The following is a description of a gene set: studied in species Mus musculus Mouse Gene Set: GOBP_RESPONSE_TO_ENDOGENOUS_STIMULUS Any process that results in a change in state or activity of a cell or an organism (in terms of movement, secretion, enzyme production, gene expression, etc.) as a result of a stimulus arising within the organism., and this is the list of marker genes: Crebbp, Prlr, Dab2ip, Lpin1, Scx, Kcnc2, Npc1, Rbbp7, Mir206, Zfp747, Bmp8a, Gck, Otop1, Car2, Gpc3, Rack1, Sh3gl2, Ndnf, Adamts12, Fgb, Pkd1l1, Lemd2, Sh2b2, Snai2, Sgcb, Cask, Prkcd, Ripk1, Fcer1g, Apoc3, Tet1, Igfbp5, Itgb3, Cdkn1c, Serpine1, Pdcd7, Dll1, Sin3a, Smurf2, Lyn, Ptk2, Strn3, Lepr, Aqp1, Ndel1, Myd88, Trem2, Erfe, Pdk4, Notch1, Inhbb, Tgfbr3, Ovol2, Mir223, Agxt, Nrp2, Magi2, Dcp1a, Zfp747l1, Ints9, Phip, Axl, Sox9, Map1b, Emd, Ppp3ca, Abcb1a, Thbs1, Bcar3, Lpl, Fam83g, Wnt10b, Tek, Akap8, Akr1c13, E2f1, Rdx, Ctsb, Enpp1, Hmgb1, Acod1, Esrrb, Tbl1x, Mir146, Igf1, Gjb2, Brms1, App, Ezh2, Cdh13, Gstp1, Ucp2, Epb41l5, Rps3, Fgf20, Adamtsl2, Sh3glb1, Creb1, Gria1 (NCBI Gene Id 72995), Lpin3, Mc4r, Epha2, Prlh, Scgb2a2, Bmp5, Pparg, Hgf (hepatocyte growth factor), Slit3, Cdkn1a, Cfl1, Dstyk, Mir219a-1 (microRNA 219a-1), Foxa1, Acta2, Asns, Gdf7, Agl, Fkbp8, Elk1, Vtn, Kdm4c, Nr0b1, Ext2, Mir142, Ctsd, Brd8, Ubr5, Ptprd, Pf4, Ntf5, Bcar1, Sp7, Padi2, Slc30a10, Fgf16, Prkd1, Zmiz1, Blvra, Cdc5lrt6, Foxc2, Mbd5, Crk (v-crk avian sarcoma virus CT10 oncogene homolog), Hmgcs2, Sfrp4, Sema6a, Wbp2, Cd109 (CD109 antigen), Irs1, Fbp1, Mir338, Bex1, Ces1f, Lta4h, Mcm7 (NCBI Gene Id 17220), Mir708, Src, Ltbp4, Pck2, Chrd, Cry1, Ccn1 (NCBI Gene Id 99596), Rhod, Mir574, Sos2, Ccna2, Elavl4, Lbh, Suds3, Nck1, Ube2o, Oxtr, Rangap1, Slx4, Slc4a7, Mir675, Rab14, Kcnj8, Fgf9, Angpt2, Mir124a-1hg, Mtor, Itga8, Skor2, Ncor2 (NCBI Gene Id 20602), Tlr4, Ogt, Pde3b, Fbxo32, Qrfprl, Il10, Cstf2, Snx1, Peg10, Hyal2, Ptpn1, Ero1a, Zeb2, Glp2r, Nog, Gas6, Mn1, Wfikkn1, Il17f (interleukin 17F), Ednrb, Kmt2a, Xbp1, Pdcd5, Adamts7, Spry1, Kat2b, Chrdl1, Ugcg, Ccl19-ps6, Ntrk3, Stat2, Itgb6 (NCBI Gene Id 93831), Actr3, Igfbp1, Alad, Sstr5, Fer, Hadh, Abcb11, Ghrl, Mir219a-2, Nodal, Foxo1, Fgfr1, Ube3a, Ces1b, Ptprk (NCBI Gene Id 19272), Lonp1, Ywhah, Abcc1, Nlk, Htra3, Tnc, Gclm, Myo5a, Bche, Rarg, Tnfrsf11b, Sco1, Pid1, Pld2, Uprt, Itga5, Gata6, Kit (KIT proto-oncogene receptor tyrosine kinase), Ift80, Lrp8, Itgb2, mt-Cytb (mitochondrially encoded cytochrome b), Naip6, Nfkbiz, Snx6, Mirlet7a-1, Trim33, Crls1, Max, Bmpr1b, Krt19, Prkaa2, Men1, Arid1a, Mmrn1 (NCBI Gene Id 70945), Pak2, Ngf, Ywhag, Card9 (NCBI Gene Id 332579), Lef1, Slc2a4, Fbn2, Gpt, Arsa, Mettl21c, Gnai2, Pcna, Slc39a14, Acsl1, Pdgfd, Hif1an, Rara, Mir486, Pdgfrb, Cdh3, Tyro3, Fat4, Tyms, Angpt1, Tnfaip6, Tie1, C1qtnf12, Runx2, Eif6, Nepn, Fgfr4, Mef2c, Ptgds, Calcr, Churc1, Jak3, Gh, Sts, Skil, Dlx3, Stat1, Appl2, Lpin2, Kmt2d (lysine (K)-specific methyltransferase 2D), Ncoa4 (NCBI Gene Id 80428), Smad1, Dag1, Yap1, Csn1s1, Pfkfb1, Hmga1, Kdm3a, Adra1b, Reg3g, Hspb1 (NCBI Gene Id 15507), Strap, Smad3, Eif2b1, Sva (seminal vesicle antigen), Twsg1, Gpr173, Hes5, Fgf23, Lats1, Acaca (acetyl-Coenzyme A carboxylase alpha), Fuz, Ntf3 (neurotrophin 3), Uri1, Taf7, Otc, Gria2, Tsc2, Rnf6 (ring finger protein (C3H2C3 type) 6), Ash2l (ASH2 like histone lysine methyltransferase complex subunit), Fos, Srsf5, Avpr1b, Col6a1, Gkn2, Adgrg1, Ppp2r5b, Shq1, Lrp5, Mir143, Smpd3, Ufsp2, Clock, Ankrd1, Mapkapk2, Bdnf, Hdac1, Msi1, Sox11, Cad, Sdcbp, Safb2, Abhd2, Ang, Serpina12, Ucn3, Bglap3, Cxcl2, Usp26, Tmem53, Bcl2 (B cell leukemia/lymphoma 2), Tgfb1i1, Sox30, Sap30l, Eif2b2, Brip1, Csnk1e, Spred1, Rap1gap, Cab39, Edn1, Itgb5, Ldlrad4, Vps13c, Bmal1, Fermt2, Selenon (selenoprotein N), Adam17, Ppp5c, Ehd1, Rhoa, Nr3c1, Eif4ebp2, Grb2, Pcsk1, Hfe, Lancl2, Pomc (NCBI Gene Id 18976), Rbbp4, Pitx2, Htr1b, Epha6, Gcnt1, Hdac9, Comt, Ccn2, Hnmt, Sos1, Mir122, Wwox, Hspa8, Gpr83, Cd2ap, Dtymk, Btg1, Gja1, Dync1li1, Pelp1, Cldn1, Adh1, Tgfb2, Ryr1, Sirt6, Blvrb, Ache (acetylcholinesterase), Prkdc (NCBI Gene Id 19090), Csrp3, Glp1r, Akt1, Mirlet7b, Lrrc25, Rarres2 (retinoic acid receptor responder (tazarotene induced) 2), Uba5, Ang4, Rbm4, Gstm5, Epha4, Dnm2, Pax9, Ces1e, Cdh5, Abcc9, Slc9a1, Cdc5lrt7, Il4, Rps6kb1, Ndn, Spi1, Col1a1, Arrb2, Hcls1, Tnfrsf1b, Ddit3, Eif2b3, Plk5, Cidea, Shoc2, Hpgd, Zbtb7a, Rcan1, Cela2a, Fut8, Wnt5a, Sstr3, Ccl21f, Cyc1, Elapor2, Bambi, Srf, A1bg, Kidins220 (kinase D-interacting substrate 220), Avpr2, Nos2, Errfi1, Adissp, Ednra, Gpld1, Ing1, Foxo4, C2cd5, Ldlr, Maob, Mst1r, Tac1 (NCBI Gene Id 68182), Sap130, Sgk1, Grip1, Fshr, Kank2, Dhrs3, Egr1, Pik3ca, Fgf2, Syk, Mir103-2, Tgfb1, Stxbp4, Gabrb1, Nfkb1, Frs3, Ptpre, Zfp366, Prkaa1, Rest, Csf1r, Mapk3, Ifnb1, Acr, Sp1, Nr4a2, Atp1a1, Akr1c18, Zdhhc17, Fgf7, Numa1, Anxa1, Usf1, Osbpl8, Cyp26b1, Pik3cd, Zdhhc7, Slc9a6, Cnmd, Cdk2, Rpl27, Gata4, Prkaca, Dusp3, Gata3, Trim72, Mir103-1, Esrra, Vegfa, Insig1, Inpp5k, Fstl1, Dbn1, Rap1gds1, Junb, Tat, Pcsk9, Kdm5d, H2az1, Brms1l, Trpv4, Actn2, Trip4, Tgfb3, Tyk2, Nqo1, Acvr2a (NCBI Gene Id 11480), Pip4k2b, Rbfox2, Pip4k2c, Tbx2, Vil1, Penk, Cadm4, Bckdhb (branched chain ketoacid dehydrogenase E1, beta polypeptide), Slc26a6, Idh1, Nr2c1, Foxh1, Il3, Adipor2, Ramp1, Ugt1a1, Mapk1, Hoxa13, Lhcgr, Gli3, Trim71, Sorl1, Itga2 (NCBI Gene Id 16398), Txnip, Tshr, Spg21, Dync1li2, Dnaaf4, Serpina3k, Gcnt2, Slco1b2, Slc2a8, Ins1, Lrit3, Dusp6, Mir26b, Nfix, Casp9, Xcl1, Cldn4, Lrp2, Nefl, Echdc3, Abcc2, Mirlet7d, Slc12a3, Foxd1, Hsp90aa1, Arpc2, Cflar, Ramp2, Apoe, Tbx1, Sult1a1, Ostn, C2, Cdc5lrt10 (cell division cycle 5 like, retrotransposed 10), Fkbp1a, Ephb1, Arid4a, Csk, Ccnd1, Pgf, Cd9, Flt3, Yy1, Cd38, Pck1, Trim68, Stc2, Ces1g, Fosl2, Pld1, Mir297-1, Mme, Ltbp1, Adipoq, Cacybp, Ptk2b, Sfrp1, Stk11, Bmpr2, Etnppl, Leprot, Frs2, Spry4, Sfr1, Tnfsf4, Mkks, Mgarp, Usp15, Col1a2, Casp3, Phox2b, Hmga2, Zbtb7b, Nr4a3, Gipc1, Nrros, Crb2, Zfp592, Ros1, Nr1d2, Ccbe1, Per1, Rab13, Nr5a2, Reg1, Hcrtr1, Grem2, Tab1 (NCBI Gene Id 66513), Agtr2, Hjv, Il12a, Hif1a, Mapk14, Fam89b (NCBI Gene Id 66159), Scnn1g, Agtr1b, Serpina1d, Lgmn, Myof, Fgfbp3, Tbx20, Hhip, Igf2, Msx1, Camk2a, Cited4, Srebf1, Mb, Sord, Pbld2, Sparc, Ddx5, Rxrb, Mir125b-1, Serpina3m, Ghrhr, Tmprss6, Pitx3, Fgf14, Vdr, Safb, Fosb, Cyp26a1, Ereg, Robo1, Bglap, Rb1, Arsb, Lrg1, Zfp36, Smurf1, Rps6-ps4, Serpinf1, Btg2, Kcnq1, Nbl1, Vsir, Med1, Reg3b, Gdnf, Pml, Gsk3b, Capn10, Etv2, Fstl3, Cep57, Rps6kb2 (NCBI Gene Id 58988), Cpeb1, mt-Nd3, Egfr, Gsk3a, Twf2, Marcks, Flt4, Cldn5, Slc2a10, Ddrgk1, Nanog, Zfp106, Rhoq, Ndst1, Ptpru, Ikbkb, Tgfbr1, Leprotl1, Rgmb, Ggh, Ggcx, Pelo, Serpina3h, Mir147, Zfp423, Snw1, Qrfpr, Slc24a4, Cat, Mup11, Tnfsf10, Phb1, Spon2, Myog, Nr1h3, Mir466, Ier2, Slc10a1, Map3k1, Ptger1, Gnas (NCBI Gene Id 78290), Rxrg, Ceacam1, Tcf4, Vwc2, Chuk, Tsc22d1, Adcyap1, Gab1, Cuzd1, Cripto, Klf2, Acsbg1, Calca, Glb1, Serpina1c, Cpeb2, Ddit4, Mtss2, Timp1, Foxl2, Xdh, Pik3r2, Steap2, Mup3, Tfpi, Apaf1, Pdpk1, Paqr8, Ptprf, Dand5, Cav2, Ar, Aldh1a2, Prdm16, Stat4, Vps11, Sesn3, Mtcl2, Pde4d, Alk, Col4a2, Pdx1, Smad2, Ptpn12, Creb3l1 (cAMP responsive element binding protein 3-like 1), Insr, Trp53, Zbed3, Ufm1, Amhr2, Nptn, Ngfr (NCBI Gene Id 18053), Trpv1, Kcp, Flt1, Mir16-1, Zfp36l1, Epha5, Sesn2, Eme1, Adra2a, Micall1, Nedd4, Dlx1, Ski, Nkx3-1, Srsf3, Ptprj, Got1, Dsg2, Ucn, Ahcyl1, Ntrk2, Phex (NCBI Gene Id 237149), Prl, Vstm2a, Mas1, Baiap2, Ccl21b, Braf, Foxp1, Slc27a1, Usp8, Atp1a3, Fbxl15, Gcgr, Gdf6, Lcat, Ccl21a, Grb7, Acvr1, Serpina3g, Ephb3, Bmi1, Isl1, Hspa5, Gba1 (glucosylceramidase beta 1), Knstrn, Eng, Ccl21d, Casr, Mapk7, Sox5, Park7, Irs2, Ndp, Nus1, Ccl19-ps5, Parp1, Hgs, Pde8a, Lgals9, Fgf12, Ncf2, Smad7, Eef2k, Pklr, Mir451a, Epn2, Spp1, Pkm, Fhl2, Shisa2, Fyn, Socs5, Prdm14, Reg2, Tgif1, Sox10, Cav3, Zeb1, Atp2b1, Cdc5lrt5, Mir126a (NCBI Gene Id 387145), Fndc4, Cdc5lrt9, Ddr2, Fgf3 (NCBI Gene Id 14174), Akt2, Lrrc32, Tsc1, Eif4e, Foxo3, Mir18 (NCBI Gene Id 387135), Ptgdr, Lox, Chst11, Mir207, Mir494, Acap2, Ocstamp, Cdc5lrt1, Cyp27b1, Mir329, Cd68, Efna5, Spred2, Vwc2l, Smad5, Fgfr2, Fgfbp1, Kbtbd2, Wnt7a, Met, Anxa5, Prkci, Pnpt1, Coro1b, Garem1, Mir3065, Nrp1, Ncoa5, Trib3, Sik2, Adtrp, Abca3, Hes1, Ugt1a6b, Zpr1, Eif2b5, Postn, Flrt1, Aldh3a1, Hmox1, Tacr1, Dsg4, Stc1, Rock2, Lhx1, Cnot2, Musk, Foxc1, Fam114a1, Akr1c19, Fasl, Wnt2, Rbpms2, Ceacam2, Rerg, Sox6 (SRY (sex determining region Y)-box 6), Tigar, Pde3a, Tob1, Tcf12, Axin1, Trim25, Mus81, Gcg, Shc1, Gnai1, Ccl19-ps1, Kdm6a, Map2k1, Zfhx3, Megf8, Snx5, Fgf18, Tgfbr2, Hoxa11, Cckar, Myocd, Vgf, Slc2a1, Serpina1e, Bag4, Insrr, Rnf14, Crim1, Uso1, Zfp703, Gata5, Sst, Ncl, Fbn1, Gnrh1, Thrb, Gpx1 (NCBI Gene Id 14775), Prokr1, Adamts3, Sort1, Pak1, Trarg1 (trafficking regulator of GLUT4 (SLC2A4) 1), Insig2, Esrrg, Tmem100, Ep300, Cbl, Mfn2, Tgfbr3l, Cyfip2, Bbs4, Map2k3, Il1rn, Esr2, Epha8, Grem1, Mzb1, Rapgef1, Srsf6, Wfikkn2, Nfe2l2, Fas, Aldh1a3, Tpr, Egr3, Tomm70a, Inhba, Pim1 (proviral integration site 1), Stat5a, Ephb4, Cps1, Prkcg, Flcn, Prkce, Hdac8, Fkbp4, Nucks1, Hrg, Serpina3f, Scn11a, Dlx5, Lncbate10, Aanat, P2ry6, Dmd, Mmp2, Eid2, Trim24, Cyfip1, Agtrap, Reg3a, Ecsit (NCBI Gene Id 26940), Slc34a2, Epo, Smad4 (SMAD family member 4), Vps54, Lnpep, Pten, Cyp1b1, Stk16, Crh, Ctsh, Cdc5lrt8, Adrm1, Prkca, Iqgap1, Tmem108, Fkrp, Heyl, Ptf1a, Zfp764l1, Myo1c, Tmem107, Erbb4, Oxt, Dab2, Serpina3c, Pagr1a, Sinhcaf, Syap1, Ins2, Ddx17, A2m, Il17rd, Areg, Cyp11b1, Gpc1, Ang5 (NCBI Gene Id 503844), Rxfp1, Sstr2 (somatostatin receptor 2, NCBI Gene Id 20606), Pkd2, Fst, Crhr1, Ccl2, Spart, Npffr1, Gprin3, Has2, Tlr6, Ces1h, Crhbp, Stk39, Hpn, Cav1, Ide, Itga3, Mup2, Bcl9l, Il1b, Sostdc1, Nono, Ddr1, Stat5b, Fgf5, Ufl1, Atp5f1a, Crkl (v-crk avian sarcoma virus CT10 oncogene homolog-like), Gclc, Fgf8, Cib1, Ntrk1, Mir145a, Rxfp2, Wnt3a, Hmgb2, Ppm1a, Fgf1, Pax6, Meis2, Irf1, Dnmt1, Sorbs1, Plcg1 (phospholipase C, gamma 1), Ccl19-ps3, Timp4 (tissue inhibitor of metalloproteinase 4), Socs2, Rps6, Acaa1a, Capn1, Runx3, Npffr2, Prmt1, Crebrf, Cga, Hadha, Ticam1, Mir195a, Ptafr, Ncoa2, Paqr7, Gpr155, Glg1, Socs7, Adora2b, Atp1a2, Mir423, Atf2, Akap13, Pmepa1, Ptpra, Pip4k2a, Hnrnpu, Veph1, Or51e2, Fgf21, Fech, Nos3, Ofd1, Nrep, Ccl19, Bmp7, Trh, Smad9, Mir145b, Fshb, Rbm14, C1qtnf9, Hdac2, Lrp1, Map2k5, Axin2, Msx2, P2ry4, Crhr2, Adcy6, Carm1, Fzd4, Zfyve9 (zinc finger, FYVE domain containing 9), Wt1, Pou4f2, Emilin1, Gpr150, Tspan32, Fgf15, Cyp11b2, Gper1, Git1 (GIT ArfGAP 1), Gpr22, Fam20c, Naip1, Cldn18, Itgb1bp1, Mir125a, Actn4, Raf1, Bcas3, Por (NCBI Gene Id 18984), Acvrl1, Cd81, Fermt1, Nr1h2, Klf15, Ulk1 (NCBI Gene Id 22241), Ube2l3, Trim63, Mirlet7f-1, Lmtk2, Kdr, Calcoco1, Ang6 (NCBI Gene Id 630952), Umodl1, Npas4, Zfyve27, Fzd1, Stub1, Trp63, Slc27a4, Obp2a, Ctnna1, Cst11, Pik3cb, Snx25, Gatm, Dll4, Usp9x, Tmf1, Comp, Arf6, Ehd4, Angptl3, Epha10, Mir138-2, Sox2, Socs3, Ahsg, Pdcd5-ps, Kcnma1, Jun, Rbx1, Ern1, Ppard (peroxisome proliferator activator receptor delta), Tns2, Mmp19, Scap, Acvr1c, Ucn2, Smarca4, Cx3cr1, Bmp4, Ffar3, Neo1, Mstn, Irs3, Ppp2r5d, Tmem204, Ptpn2, Bmpr1a, Prkcb, Hipk2, Appl1 (adaptor protein, phosphotyrosine interaction, PH domain and leucine zipper containing 1), Sphk1, Star, Fbxw8, Pin1, Jak2 (NCBI Gene Id 98155), Aifm1, Zfp36l2, Lcn8, Rapgef2, Hap1, Atp2a2, Adgra2, Fosl1, Ctnnb1, Cdc5lrt4, Cd44, Cer1, Adam9, Ptp4a3, Zcchc12, Ppp1r9b, Scnn1a, Hras, Ctbp2, Ccr7, Mir23a, Dennd4c, Sdc1, Smarcc1 (NCBI Gene Id 20588), Becn1, Pxn, Spry2, Rab35, Ltbp3, Fgf6 (NCBI Gene Id 14177), Epha3, Mir148a, Skor1, Gdf15, Col3a1, Cpn1 (carboxypeptidase N, polypeptide 1), Htra1, Nr1h4, Ireb2, Plcb1 (NCBI Gene Id 98861), Eprs1, Atp2b4, Vps18, Klf9, Ccl19-ps4, Mars1, Rbbp5 (NCBI Gene Id 71117), Gphb5, Mat2a, Adipor1, Scnn1b (NCBI Gene Id 20277), Txn2, Agt, Mapkap1, Ncor1, Gdf2, Ctdspl2, Slit2, Zfp764, Zmpste24, Aspn, Fez1, Kat2a, Wasf1, Epha7, Tfap2b, Slc39a5, Eif2b4, Mia3, Rasl11b, Ppara, Rab10, Pik3r1, Bmncr, Prcp, Zyx, Nucb2, Dnai1, Ces1a, Dkk1, Gad2, Slc26a5, Htr7, Acvr1b, Spred3, Tnfrsf11a, Arid4b, Kcnd3, Fam107a, Smoc2, Cited2, Nudc, Gip, Rbpj, Rwdd1, Smad6, Greb1l, Cd36, Tcf7l2, Cnot3 (CCR4-NOT transcription complex, subunit 3), Rock1, Ptgs2, Hsf1, Fstl5, Sstr4, Il6, Aldob, Hsd11b2, Ccl21e (C-C motif chemokine ligand 21E), Rgma, Trerf1, Lmo3, Rap1a, Phb2, Mbp (myelin basic protein), Chrdl2, Mir672, Nkx2-1, Oprd1, Tnf, Yes1, Ang2, Ascl1, Ace, Acat1, Atp2a1, Stat3, Hivep1, Slc25a33, Cul3, Fstl4, Nr4a1, Ing2, Ror2, Cd59a, Tcf21, Jund, Fgfrl1, Gpr82, Ptges3, Skp2, Tbc1d4, Ptprv, Rab31, Fut7, Ctsl, Mylip, Shcbp1, Pik3r3, Pgr, Dcstamp, Jcad, Serpina1b, Inppl1, Mt3, Eef1a1, Sost, Bmper, Map3k7, Nos1, Cybb, Ilk, Flrt2, Rnf111, Galp, Id1, Eif4ebp1, Agtr1a, Mirlet7f-2, Flrt3, Tmem119, Dhh, Onecut1, Igfbp2, Timp3, Anxa3, Stxbp3, Lep, Ankrd26, Furin (NCBI Gene Id 78149), Srd5a2, Ptger4, Reg3d (regenerating islet-derived 3 delta), Mertk, Rarb (NCBI Gene Id 218772), Ptgfr, Tspo, Sstr1, Ghr, Mir192, Adcy8, Il12b, Akt3, Klf4, Hcrtr2, Nkx6-1, Sra1, Ugt1a6a, Ces1c, Cp, Alpi, Uchl3, Dnaja1, Mdm2, Bbs2, Akr1c12, Onecut2, Srebf2, Zfp451, Nrxn1, Ltk, Asxl1, Pappa, Cacna1a, Ccl5, Dusp22, Scube3, Pdgfb, Prkcq, Dhcr24, P2ry1, Sirt1, Ramp3, Cyp11a1, Cxcl13, Socs1, Mmp14, Cnot9, Khk, Mmrn2, Arid5a, Csnk2b, Stat6, Cul7, Npnt, Kcnc1, Itgb8, Hdac6, Ucp3, Sfrp2, Mir493 (NCBI Gene Id 100124466), Fgf22, Npr2, Mir155, Mexis, Ppargc1b, Hmgcs1, Tbc1d7, Opa1, Zfp536, Htra2, Smyd3, Daxx, Vasn, Cblc, Cdkn1b, Hoxa10, Serpina3i, Sap30, Pdk2, Mir138-1, Fbh1, Nr3c2, Ppargc1a (NCBI Gene Id 320239), Pax8, Coro1a, Thra, Uqcrfs1, Vamp2, Prmt2, Folr1, Hnrnpk, Akr1c20, Irs4, Kmt2e, Kl, Jak1, Mir210, Pals1, Dok5, Abl1, Tnrc6c, Smc1a, Gpi1, Vwa2, Gkap1, Avpr1a, Ptpn11, Rac1, Ghsr, Prkcz, Gpr21, Prkar1a, Ncoa1, Dlg1, Snrpn, Adm, Fgf4, Stmn2, Cdc5l, Wnt10a, Gpam, Timp2, Esr1, Ext1, Vegfc, Ccnd3, Pin1rt1, Rxra, Egr2, Fgfr3, Plcd1, Pias2, Kank1, Gnrhr, Naip2, Ephb2, Hyal1, Ncoa3, Bmp10, Rbp4, Me1, Nr1d1, Atp7a, Brca1, Scly, Nfia, Acta1, Ptger2, Acvr2b, Zfp128, Agrp, Cnot1 (NCBI Gene Id 338501), Fgf17, Calr, Bmp2, a, Apln, Grb10 (NCBI Gene Id 67977), Nr5a1, Ces1d, Acbd7, Lpxn, Wnt1, Gdf3, Col2a1, Ren1, Hhex, Prokr2, Epha1, Pdcd6, Kif16b, Dcn, Mir21a, Serpina3n, Nkx2-2, Igf1r, F7, Cdo1, Pbld1, Vegfd, Cited1, Sulf1, Oprk1, Ucp1, Fgf10, Rasa1, Lats2, Ass1, Abca2, Kdm5b, Akt1s1 (AKT1 substrate 1), Arap1, Cyp7b1, Meak7, Pdcd4, Grb14, Rab8a, Ark2c, Cilp, Cdkn2b, Cntnap2, Apc, Klb, Pdgfra, Notch2, Ret, Ctsk (cathepsin K), Spint1, Hsp90ab1, Srarp, Itgb1, Ngly1, Cpne3, Gata1, Gdf10, Bloc1s6, Mup5, Bglap2, Scgb1a1, Bsg (basigin), Il17a (interleukin 17A), Twist1, Mup4, Ibsp, Lemd3, Cd63, Cry2, Gdf5, Gfra1, Mup1, Sulf2, Epm2aip1, Prkd2, Rela, Grk2, Mirlet7e, Mtmr4, Vegfb, Retn, Zdhhc16, Mir181d, Il18, Myod1, Cd24a, Serpina1a, Has1, Nsmf, Adra1a, Bmp8b, Runx1, Alpl, Erbb2, Th, Wdtc1, Akr1c6, Wnt4, Mmp13, Bmp6